Given this list of marker genes TNC, FGF2 (NCBI Gene Id 2247), COL1A2 (collagen type I alpha 2 chain), CASK, ITGAV, COL5A2, ITGB4, ITGB1 (NCBI Gene Id 3688), ACTN1, TGFB1, SDC1, COL5A1, ITGB3, ITGA6 (integrin subunit alpha 6), ITGB5, VTN, COL1A1, COL3A1, SDC4, SDC2, PRKCA, SDC3, THBS1, TRAPPC4, ITGA2, COL5A3, FN1, here is a description of the gene set: Syndecans are type I transmembrane proteins, with an N-terminal ectodomain that contains several consensus sequences for glycosaminoglycan (GAG) attachment and a short C-terminal cytoplasmic domain. Syndecan-1 and -3 GAG attachment sites occur in two distinct clusters, one near the N-terminus and the other near the membrane-attachment site, separated by a proline and threonine-rich 'spacer'. Syndecan ectodomain sequences are poorly conserved in the family and between species, but the transmembrane and cytoplasmic domains are highly conserved. Syndecan-1 and -3 form a subfamily. Syndecan core proteins form dimers and at least syndecan-3 and -4 form oligomers (Asundi & Carey 1995, Shin et al. 2012). Syndecan-1 is the major syndecan of epithelial cells including vascular endothelium. Syndecan-2 is present mostly in mesenchymal, neuronal and smooth muscle cells. Syndecan-3 is the major syndecan of the nervous system, while syndecan-4 is ubiquitously expressed but at lower levels than the other syndecans (refs in Alexopoulou et al. 2007). The core syndecan protein has three to five heparan sulfate or chondroitin sulfate chains, which interact with a variety of ligands including fibroblast growth factors, vascular endothelial growth factor, transforming growth factor-beta, fibronectin, collagen, vitronectin and several integrins. Syndecans may act as integrin coreceptors. Interactions between fibronectin and syndecans are modulated by tenascin-C. Syndecans bind a wide variety of soluble and insoluble ligands, inckluding extracellular matrix components, cell adhesion molecules, growth factors, cytokines, and proteinases. As the cleaved ectodomains of syndecans retain the ability to bind ligands, ectodomain shedding is a mechanism for releasing soluble effectors that may compete for ligands with their cell-bound counterparts. Shed ectodomains are found in inflammatory fluids and may induce the proliferation of cancer cells. Reactome Pathway: Syndecan interactions part of: Non-integrin membrane-ECM interactions studied in species Homo sapiens